The following is a description of a gene set: Human Gene Set: WP_HEPATITIS_B_INFECTION Hepatitis B infection species: Homo sapiens, and this is the list of marker genes: NFATC2, CREB3L3, IFNA13, APAF1, NFATC4, TNF, PIK3CA, AKT3, IKBKB, MAPK14, NRAS, NFKB1, ATF4, MAPK10, YWHAZ, CASP3, SLC10A1, PRKCG, IFNA10, DDX3X, PRKCA, TYK2, IRAK4, TRAF6, IFNA14, TICAM1, MAPK8, JAK2, EP300, STAT1, SMAD2, MYD88, TGFB1, ATF2, TGFB3, PCNA, TICAM2, STAT5A, STAT4, IFNA1, IKBKG, MAPK9, IFNB1, PRKCB, IKBKE, PIK3R3, CASP8, PIK3CD, IFNA6, IFNA21, DDB1, TIRAP, PIK3R1, IFNAR1, CASP9, EGR2, ELK1, DDB2, YWHAB, STAT3, MYC, RAF1, CDKN1A, CASP10, SOS1, IFIH1, BIRC5, IFNA4, CREB3, MAP2K7, YWHAQ, CREB5, TBK1, MAPK3, SOS2, MAP2K3, FADD, CYCS, MAPK12, JUN, MMP9, TLR4, HRAS, TLR2, AKT2, IL6, ARAF, PIK3R2 (phosphoinositide-3-kinase regulatory subunit 2), CHUK, IRAK1, MAP3K1, CREBBP, CREB3L2, VDAC3, CREB3L4, ATF6B, NFATC1, EGR3, STAT6 (NCBI Gene Id 6778), NFATC3, TAB2, ATP6AP1, FOS, IRF3, MAP3K7, IFNA2, BAX, IFNA5, MAPK1, BCL2, TLR3, TGFBR2 (NCBI Gene Id 7048), AKT1, MAPK13, RIGI, IFNA16, STAT2, SRC, KRAS, PTK2B, IFNA7, TAB1, PIK3CB, STAT5B, JAK1, SMAD4, CREB3L1, BID, MAP2K6, BAD, HSPG2, MAVS, MAP2K4, FAS, RELA, GRB2, IFNA8, MAPK11, CREB1, IRF7, IFNA17, TGFB2, MAP2K2, TGFBR1, MAP2K1, SMAD3, TRAF3, FASLG, JAK3, BRAF, CXCL8